Given this list of marker genes Tpi-rs5, Platr6, E030030I06Rik, Txlnb, Semp2l2b, Gm7584, Gm19791, Heca, Gm4922, Map7, Gm4895, C920009B18Rik, Gm40608, Gm10827, Hmgb1-ps8, Tcf21, Ifngr1, Olig3, Pde7b, Myb, Reps1, Ect2l (epithelial cell transforming sequence 2 oncogene-like), Gm20149, Gm2467, Gm10825, Eya4, Gm23839, Nhsl1, Map3k5, Gm33104, Il20ra, H60b, Gm7672, Gm48249, 4930455C13Rik, Gm48537, Ahi1, 4933406P04Rik, Il22ra2, Mtfr2, Gm33619, Gm33332, Pex7, Gm10824, 1700020N01Rik, 4930520K02Rik, Gm1972, Gm18942, Hbs1l, Raet1d, Tnfaip3, Gm7678, Bclaf1, Gm5420, Gm17794, 1700021A07Rik (RIKEN cDNA 1700021A07 gene), Aldh8a1, Gm16531, Mir6413, 4930405J17Rik, 1700124M09Rik, Slc35d3, Hebp2, Slc2a12, Arfgef3, Gm17230, Gm17229, Abracl, Gm18637, Rpl32l, Gm32926, Gm7213, Gm8540, Gm20139 (predicted gene, 20139), Gm2539, Raet1e, Gm5421, Gm26740, Sgk1, Gm26585, Ccdc28a, Gm30285, Rps2-ps3, Tbpl1, Perp, Fkbp1a-ps2, Gm33728, Gm10826, Gm20655, Mir7663, 4930444F02Rik, here is a description of the gene set: studied in species Mus musculus Mouse Gene Set: chr10A3